The following is a description of a gene set: species: Homo sapiens B lymphoma expression clusters. Human Gene Set: MODULE_361, and this is the list of marker genes: LBH, ITGB7, CD53, ATP2A3 (ATPase sarcoplasmic/endoplasmic reticulum Ca2+ transporting 3, NCBI Gene Id 489), VANGL1, GLRA3, BIN2, DIRAS2, DBP, RIPOR3, FCMR, SEPTIN6, HVCN1, MARCHF1, CTLA4, AXIN1, CD37, SPINT2, C3orf36, CTSZ, KLHL41, CMKLR1, COQ9, UTY, MX1, TASL, ABCC5, ALOX5 (arachidonate 5-lipoxygenase), TXLNGY, TRDD3, FCRLA, IL10RA, GABBR1, COL4A4, TP53I13, ZNF587, CXCR4, DGKD, SMCHD1, TXNIP, PRKCB, SOX6, PDE2A, ROR1, POLR3B, ANKRD28, FAM53B, NACAD, P2RY10, IGHG3, CD200, ADAM28, CCDC186, FOXP1 (NCBI Gene Id 87246), BACH2, CTSF, TOR1B, APOBEC3G, SHC2, DPEP2, TCF7, SPON2, IL24, RCSD1, STK33, ZFHX2, BTG2, SPPL2A, FCRL2, CD48, ITM2C, RAPGEF6, PLGRKT, IL4R, CD5, TMEM97, TRAPPC13, SEL1L, NR2E1, HLA-DRB3, AMD1, MTBP, COL19A1, RUBCNL, HDAC9, TNFAIP2, PLCL2, COA7, RABIF, TTLL2 (tubulin tyrosine ligase like 2), ZNF395, PORCN, MED29, FAM200C, USP2, FGR, UNC5D, CD24, SLC24A3, DNAH11, RIPK4 (NCBI Gene Id 54101), G6PC3, KCNA3, SLC27A5, NAALADL1, CSMD2, OSBPL10, FLRT2, RAX2, CNR2, HSD17B11, SELP, ZNF292, IGHM, ADA2, ADGRE2, TSPOAP1, PRMT3, RSAD2, PLAC8, MED12L, CACNG4, SPRR1A, BCL2, KIAA0753, NRIP2, LRRC19, TCL1A, ZFP36L2, PTCRA, ICAM3, HIKESHI, BLOC1S5, ADAM19, FCER2, HEATR6, RPAP3, DEFA1, KCNQ5, MECP2, SP140, FANCF, ST6GAL1, TSPAN32, IRF8 (NCBI Gene Id 3394), NEK11, BANK1, FCRL1, ZNF423